Given this list of marker genes TTLL1, SKOR2, SLC25A46, KIF14, LDB1, COQ8B, B4GALT2, WHRN, ARCN1, AARS1, CEND1, KLHL1, GBA1, DLL1, LHX5, NAGLU (NCBI Gene Id 4669), HERC1, RERE, LHX1, AGTPBP1 (ATP/GTP binding carboxypeptidase 1), RORA, HSPA5, SEZ6, FAIM2, TTC21B, MYH10, SPTBN2, UQCRQ, ATP7A, FOXP2, here is a description of the gene set: species: Homo sapiens Human Gene Set: GOBP_CEREBELLAR_PURKINJE_CELL_LAYER_DEVELOPMENT The process whose specific outcome is the progression of the cerebellar Purkinje cell layer over time, from its formation to the mature structure. The Purkinje cell layer lies just underneath the molecular layer of the cerebellar cortex. It contains the neuronal cell bodies of the Purkinje cells that are arranged side by side in a single layer. Candelabrum interneurons are vertically oriented between the Purkinje cells. Purkinje neurons are inhibitory and provide the output of the cerebellar cortex through axons that project into the white matter. Extensive dendritic trees from the Purkinje cells extend upward in a single plane into the molecular layer where they synapse with parallel fibers of granule cells.